The following is a description of a gene set: Binding to a CARD (N-terminal caspase recruitment) domain, a protein-protein interaction domain that belongs to the death domain-fold superfamily. These protein molecule families are similar in structure with each consisting of six or seven anti-parallel alpha-helices that form highly specific homophilic interactions between signaling partners. CARD exists in the N-terminal prodomains of several caspases and in apoptosis-regulatory proteins and mediates the assembly of CARD-containing proteins that participate in activation or suppression of CARD carrying members of the caspase family. Human Gene Set: GOMF_CARD_DOMAIN_BINDING species: Homo sapiens, and this is the list of marker genes: CARD14, BCL10, MAVS, RIPK2, IRGM, NOD2, CARD11, CASP4, CARD18, CARD16 (NCBI Gene Id 114769), CARD8, CARD19, NOD1, CASP1, CARD9